The following is a description of a gene set: studied in species Homo sapiens Human Gene Set: GOCC_PHOSPHORYLASE_KINASE_COMPLEX An enzyme complex that catalyzes the phosphorylation of phosphorylase b to form phosphorylase a., and this is the list of marker genes: PHKG2, PHKA1, PHKG1 (NCBI Gene Id 5260), PHKB, PHKA2 (NCBI Gene Id 5256)